Given this list of marker genes Hes1, Gli3, Mettl3, Hes5, Rhoa, Lrp6, Nfix, Lef1, Mettl14, here is a description of the gene set: studied in species Mus musculus The process in which neuroepithelial cells of the neural tube give rise to radial glial cells, specialized bipotential progenitors cells of the forebrain. Differentiation includes the processes involved in commitment of a cell to a specific fate. Mouse Gene Set: GOBP_FOREBRAIN_RADIAL_GLIAL_CELL_DIFFERENTIATION